The following is a description of a gene set: Nuchal rigidity Human Gene Set: HP_NUCHAL_RIGIDITY species: Homo sapiens Resistance of the extensor muscles of the neck to being bent forwards (i.e., impaired neck flexion) as a result of muscle spasm of the extensor muscles of the neck. Nuchal rigidity is not a fixed rigidity. Nuchal rigidity has been used as a bedside test for meningism, although its sensitivity for this purpose has been debated., and this is the list of marker genes: TICAM1, TBK1, PTPN22, TRAF3, UNC93B1, ATP1A2, TLR3, SCN1A, FAS, IRF3, PRRT2, CACNA1A